Given this list of marker genes UNK, SSX2IP, DAB2, SLC16A6, SGMS1, CALD1, BTBD10, PAPOLB, IQSEC2, PFKFB3, SPRED1, U2SURP, FYCO1, OSR1, CMTR2, PDE3B, USP3, PAPOLA (poly(A) polymerase alpha), KLHL15, RB1CC1, KLF9, BBX, DNAJC27, FZD3, C2orf69, ABCG4, ARHGAP26, SMOC2 (NCBI Gene Id 64094), DUSP2, CMPK1, PCDHA12, LYPD6, ZBTB18, CROT, BMPR2, OSM (oncostatin M), RRM2, MIDN, SNX16, MKNK2, PCDHA4, ATG2B (autophagy related 2B), GNPDA2, FNDC3B, SH3BP5, TNKS2, TNFAIP1, PCDHA6, FAM13C, ZFYVE9, PLAG1, STK17B, ZSCAN20, ARHGEF11, FBXO48, FAM210A, RNF6, SLAIN2, ORMDL3, CERCAM, STK38, EIF4A2, USP24, ABL2, AMER2, HBP1, EEIG1, APP, CDC37L1, GPR137C, PCDHAC2, NAPEPLD, LZIC, RGL1, PITPNA (phosphatidylinositol transfer protein alpha), PCDHAC1, ARHGAP12, REST, HLF, ARID4A, MAPK1, ELK3, RAB22A, BEST3, CYBRD1 (cytochrome b reductase 1), ARHGEF18, KATNAL1, PHIP, RETREG2, ZNF25, CNOT4, RAB10, PBX3, CSRNP3, UBE3C, SMOC1, SMAD4, SNTB2, ZNF264, SFMBT1, TMEM168, ATXN1L, RAPH1, STXBP5, SLMAP, EGR2, SOS1, TGFBR2, EMSY, SOX4, FAM199X, PFKP, DERL2, TIAM1 (TIAM Rac1 associated GEF 1), SLC46A3, ARHGEF28, TMEM127, PCDHA2, TRIM36, MAGI3, ZBTB4, TPRG1L, AFG1L, OSTM1, SCAMP2, NUP35, FLT1, USP28, CENPQ, DDX5, GNS, NFIB, MEX3D, RNF128, THRA, MFSD8, LMO3, HTR2A, CFL2, TMEM138, SUSD6, MTF1, CMKLR1, ZNF827, IRF1, SAR1B, SMAD5, SEMA4B, DDHD1, DOCK4, ERC1, PRR14L, ZNF148, LRRC55, CAMTA1, TAFA1, KLHL2, ZBTB8A, TET3, APCDD1, RASGRF2, DRD1, EZH1, GNB5, RGMB (repulsive guidance molecule BMP co-receptor b), TAOK3, MASTL, MOSMO, ANKIB1, LIMA1, POLR3G, YOD1, ZDHHC9, LIMK1, PCDHA13, PTHLH, SERP1, ANKRD33B, KMT5B, SESN3, TANC1, SEMA7A, NPAS2 (neuronal PAS domain protein 2), DPYSL5, BRMS1L, NDEL1, CCDC71L, MAP3K14, ATAD2, PAK5, PCDHA10, FBXO31, RPS6KA5, PPP3R1, DNAL1 (NCBI Gene Id 83544), AKAP11, PLAGL2, KMT2A, RACGAP1, SALL1, EPHA5, NFAT5, SH3PXD2A, NR2C2, ARID4B, FGD4, TET1, SLC4A4, BNC2, PCDHA7, MAP3K2, BCL11B (BCL11 transcription factor B), ST3GAL1, LASP1, AKAP13, CEP120, ATP12A, TSG101, PKD2, ADAM9, OCRL, OLFM3, NBEA, USP46, FAT2, TMEM64, ANKRD29, RPS6KA4, FAM13A, EIF5A2, PRR16, S1PR1, PURB, GUCY1A1, UNC80, ERAP1, SQSTM1, PARD6B, MAPK4, IL6ST, TBC1D9 (TBC1 domain family member 9), PTPN4, FOXJ3, ACSL4, C14orf28, FSD1L, ZFYVE26, CDC23, TRIM3, PKD1 (polycystin 1, transient receptor potential channel interacting), SLC49A4, FRS2, KIAA0513, LHX6, HAUS8, EPHA4, NR2C1, KMT2B, NANOS1, FEM1C, IL1RAP, AGO1, FNBP1L, FBXO21, P2RX4, NPAT, RRAS2, CTSK, MYLIP, LPGAT1, SACS, TMX3, MYNN, UEVLD, LYST, PEX5L, ZNF202, MAPRE3, SERF1A, CC2D1A, PCDHA5, SERF1B, RBL2, FBXL5, HSPA8, ANKRD50, PPP1R15B, NRIP3, RASD1, ENTPD4, E2F5, IGSF10, USP31, RLIM, SLC17A7, CRY2, CREB5, HYCC2, CNOT7, VASH2, DENND10 (NCBI Gene Id 404636), ZNF597, MCF2L, NIBAN1, PPP1R3B, RAB5B (RAB5B, member RAS oncogene family), GRAMD1A, RAB8B, EGLN3, PTGDR, BCL2L11, ARHGEF3, CD274, AHNAK, NCOA3, ROCK2, NABP1, PPP1R21, ITGB8, CCND1 (NCBI Gene Id 893), UBXN2A, RASL11B, STRIP2 (striatin interacting protein 2), TENM1, PRR15, RAB30, KIAA1191, NTNG1, BNIP2 (BCL2 interacting protein 2), CAPRIN2, WFS1, ZBTB7A, AKTIP, TMBIM6, TRPV6, MED12L, PSD, SLC4A8 (solute carrier family 4 member 8), TNKS1BP1, TSPAN9, UXS1, KCNJ10, F3, ENPP5, KIF26B, PXYLP1, PANX2, ZBTB9, TRIP10, TMEM167A, ANKH, NIN, GAB1, LCOR, B3GALT2, NAGK, NACC2, SSH1, PGM2L1, NCKAP5, BTBD7, VANGL1, HEG1, PTPDC1, NKIRAS1, JPT1, ZNF280B, PRCP, UBE2Q2, PLXNA1, WDR37, BHLHE41, SCN1A, FCHO2, SEPTIN2, SNX8, ZHX2 (NCBI Gene Id 22882), LRP8, ZNF512B, SAMD12, ADARB1, SRCIN1, CTSA, TBC1D20, PLXDC2, CREB1, EPHA7, XRN1, SCN2B (sodium voltage-gated channel beta subunit 2), GPR137B, PPP6C, TBC1D8B, SLC24A2, LRPAP1, BAHD1, LDLR, MYO5B, MCL1 (NCBI Gene Id 4170), FGD5, NEDD4L, PCDHA1, ZNFX1, TAOK1, ZNF704, CNOT6, PCDHA11, LAMA3, CEP170, ZNF652 (NCBI Gene Id 22834), GPR6, AGFG2, ZBTB21, CXCL6, ULK1, TFAM, REV3L, IRF9, ZBTB41 (zinc finger and BTB domain containing 41), NTN4, REPS2, RHOC, BICC1 (NCBI Gene Id 80114), CNRIP1, GOSR1, OTUD4, OXR1 (NCBI Gene Id 55074), RSRP1, ETV1, ABI1, PXK (PX domain containing serine/threonine kinase like), SLC40A1, PCDHA8, PRDM6, RNH1, AGTPBP1, CORO2B, FRMD6, ISM2, FAM219B, PLEKHA3, WDFY3, FAT4, RUFY2, GPATCH2, DNAJC16, ANKRD52, ZFP91, ZBTB20, USP32, MAP10, ANKRD17, ZFAND4, TMEM100, ZNF236, MAP7, CD69, RAP2C, TGM2, DNAJB9, PDGFRA, LDLRAP1, NEUROG1, TAGAP, PPARA, SLC33A1, ARMC8, ABCA1, ARHGEF10, L3MBTL3, RORA, CHP2, SERTAD2, HIF1A, PTPN21, CNOT6L, NPLOC4, NHLRC3, WNK3, KCNK10, AAK1, DCUN1D1, C2CD2, SSH2, NFIC, ANO6, MTMR3 (myotubularin related protein 3), GOLGA1, MMP24, ZNF800, KIF3B, MFN2, NIPA1, EREG, TOPORS, AGFG1, NAA30, SUCO, RUNX3, PTPRD, ZBTB33, DYNC1LI2, HS3ST5, SALL3, BICD2, GXYLT1, KCNB1, SLITRK3, MFAP3L, KIF23, KAT2B, DENND5B, PTPN3, HECTD2, URI1, ZDHHC1 (zinc finger DHHC-type containing 1), CEP97, SRGAP1, TRIM37 (tripartite motif containing 37), USP6, REEP3, E2F1, MAP3K8, EFCAB14, ZFPM2, PIK3R1, PDCD1LG2, ITPRIPL2, ANKFY1, RBL1, GPR63, ZC3H12C, PAG1, VLDLR, LRCH1, DCBLD2, ARHGAP1, TRIP11, WDFY2, PCDH15, TNFRSF21, RPS6KA6, MARCHF8, MYT1L, SCAMP5, BRWD1, FAM117B (NCBI Gene Id 65069), KLF11, BTG3, RBBP7, CRYBG3, RORC, SYTL4, PRRG1, MKRN1, SPOPL, PGBD5, RGMA, CAPN15, HPS5, PDLIM5, GLIS3, RRAGD, AP2B1, ATL3, VSX1, RAB11FIP5, ENTREP2, ZNF367, ATG16L1, LAPTM4A, TXNIP, TMEM265, CHD5, RCCD1, MAP3K9, TRAPPC14, ST6GALNAC6, ELK4, TP73, GABBR2, LRIG1, RNASEH2B, MINK1, TRDN, PCDHA3, RAB11FIP1, ANKRD13C, PHC3, STAT3, STYX, FJX1, CLIP4, ABHD2 (abhydrolase domain containing 2, acylglycerol lipase), KLHL28, DPYSL2, TM2D2, UNKL, SRPK2, DUSP8, FBXL3, HAS2, STK11, CLOCK, SLC16A9, RETREG3, PSG3, KPNA2, ITGA4, CHRM2, EPS15L1, FOXK2, SLC22A23, ZXDA, CCNG2, SIKE1, here is a description of the gene set: species: Homo sapiens Human Gene Set: MIR93_5P Genes predicted to be targets of miRBase v22 microRNA hsa-miR-93-5p in miRDB v6.0 with MirTarget v4 prediction scores > 80 (high confidence targets). from publication Chen Y, Wang X (PMID 31504780)